The following is a description of a gene set: Human Gene Set: GOBP_VASCULAR_PROCESS_IN_CIRCULATORY_SYSTEM studied in species Homo sapiens A circulatory process that occurs at the level of the vasculature., and this is the list of marker genes: SLC2A10, ABCC1, INS (insulin), TNF (tumor necrosis factor), KNG1, ADRA1D, VEGFA, SLC13A3, NOS1, SLC6A13, ROCK1, NOS3, PDE2A, FLVCR2, SLC6A9, SLC15A2, PDE3A, ZEB2, SLC7A5, SLC2A13, ABCC4, EXT1, CD38, SLC16A7, P2RX1, EDN3, SLCO2B1, DRD5, CTNNBIP1, SLC6A17, SLC6A20, SLC6A1, GJA5, FERMT2, GUCY1A1 (NCBI Gene Id 2982), SLC6A4, BCR, NPPC, TJP3, INSR, BDKRB2, SRC, CEACAM1, GCLM, LRP2, UCN (urocortin), OCLN, CDH5, HBB, MANF, FABP5, KEL, SLC1A2, SLC2A1, TRPV4, SLC8A2, APOE, SLC6A6, PPARD, UTS2 (urotensin 2), SLC22A2, ADD3 (NCBI Gene Id 121), SLC7A2, DOCK5, SOD1, EXT2 (exostosin glycosyltransferase 2), VEGFB, SLC44A1, ADRA2C, AKAP12 (NCBI Gene Id 9614), SCARB1, DRD1, SLC2A4, AVPR1A, ABL1, AVP, HTR1A, CASR, EDNRB, ADORA2A, ROCK2, SLC22A8, LRP3, ADRA1B, TGFB1, MTNR1B, AZU1, PECAM1, SLCO3A1, SLC1A1, SLC2A3 (NCBI Gene Id 94827), COMP, SLC38A1, SLC16A1, MAP2K1, ABCC3, DDAH1, TJP1, RHOA, AGT, KCNMB2, TBXA2R, SLIT2, ADRA2B, TACR2, SLC24A3, SH3GL2, BMP6 (bone morphogenetic protein 6), NPPA, PLOD3, FOXC1, SLC7A3, ECE1, IRAG1, KAT2B, SLC29A2, AGER, SLC5A6, HRH1, KCNJ8, BMPR2, CALCA, F2RL1, FGB, ATP1A2, CLDN5, ANGPT1 (angiopoietin 1), NHERF1, P2RY1, SCPEP1, GPX1, MAS1, SLC29A1, ACTA2, AVPR1B, MKKS, PLEC, ADORA1, RAP1GDS1, PTP4A3, SLC16A12, ABCC2, SLC16A2, SLC12A2, GPR4, GPER1, P2RY2, PTPN11, FGA, SLC1A4, ATP1B2, NPPB, HRH2, CRP, ACE2, NTS, SLC22A5, KCNMB4, SLC4A4, ABCA2, ATG5, SLC8A1, BLOC1S6, SLC27A1, FGFBP3, TFRC, ASIC2, ATP2A3, PIK3C2A (NCBI Gene Id 5286), OXTR, HTR7, AMOT, MIR153-1, ADORA2B, SLCO1C1, GRIP2, APLN, SLC38A3, ITGA9, UTS2R, PER2, SLC19A1, RAMP2, SLC4A8, MIR138-1, PLVAP, DOCK4, DBH, CPS1, ADRB2, ACE, FOXC2, F2R, TJP2, SLC38A5, HTR1D, EDNRA, MIR92A1, LRP1, TRPM4, SERPINF2, ABCC5 (NCBI Gene Id 10057), FGG, MMP2, GAB1, AGTR2, SLC38A2, C2CD4B, ATP1A4, UTS2B, LEP, S100A1, ADRB1, CD36, STUB1 (NCBI Gene Id 10387), TEK, CAV1, AGTR1, SMTNL1, ITGB1, ITGA1, VSTM4, MRGPRD, EDN1, GCLC, ABCB1 (ATP binding cassette subfamily B member 1), ADRA1A, MIR21, ITGB1BP1, NPR1, HTR2A, ITGA4, SLC22A3, ARHGAP35, HTR2B, ABCC9, SVEP1, YES1 (NCBI Gene Id 7525), ATP8A1, AVPR2, KCNMA1, ZDHHC21, ARHGAP42, SLC28A2, SLC4A3, SLC1A3, FAAH (NCBI Gene Id 2166), ENSG00000274276, SLC1A5, SLC22A1, SLC7A8 (NCBI Gene Id 23428), TBXAS1, SCNN1B, EDN2, SLC7A1, ADCY6, ADRB3, SLC5A5, ADRA2A, MIR23A, ABCG2, ATP2B4, SLC29A4, BBS2, HTR1B, TACR1, KLF2, ADM, RGS2, SLC5A1, C2CD4A, PRKG1, SLC5A3, LEPR, ABCC8, KCNA5, PTPRJ, MFSD2A, ATP2B1, SLC27A4, CBS, SOD2